The following is a description of a gene set: Decreased libido species: Homo sapiens Human Gene Set: HP_DECREASED_LIBIDO Decreased sexual desire., and this is the list of marker genes: NR0B1, TRANK1, CDKN1B, MEN1, BMP6, AIP, CDKN2B, CDKN2C, HFE, GPR101, CDH23, CDKN1A, FSHB